The following is a description of a gene set: Inflammatory genes down-regulated in mammary carcinoma cells after stimulation with TGFB1 for 1 hr. Mouse Gene Set: BIERIE_INFLAMMATORY_RESPONSE_TGFB1 Transforming growth factor (TGF)-beta signaling has been associated with early tumor suppression and late tumor progression; however, many of the mechanisms that mediate these processes are not known. Using Cre/LoxP technology, with the whey acidic protein promoter driving transgenic expression of Cre recombinase (WAP-Cre), we have now ablated the type II TGF-beta receptor (T beta RII) expression specifically within mouse mammary alveolar progenitors. Transgenic expression of the polyoma virus middle T antigen, under control of the mouse mammary tumor virus enhancer/promoter, was used to produce mammary tumors in the absence or presence of Cre (T beta RII((fl/fl);PY) and T beta RII((fl/fl);PY;WC), respectively). The loss of TGF-beta signaling significantly decreased tumor latency and increased the rate of pulmonary metastasis. The loss of TGF-beta signaling was significantly correlated with increased tumor size and enhanced carcinoma cell survival. In addition, we observed significant differences in stromal fibrovascular abundance and composition accompanied by increased recruitment of F4/80(+) cell populations in T beta RII((fl/fl);PY;WC) mice when compared with T beta RII((fl/fl);PY) controls. The recruitment of F4/80(+) cells correlated with increased expression of known inflammatory genes including Cxcl1, Cxcl5, and Ptgs2 (cyclooxygenase-2). Notably, we also identified an enriched K5(+) dNp63(+) cell population in primary T beta RII((fl/fl);PY;WC) tumors and corresponding pulmonary metastases, suggesting that loss of TGF-beta signaling in this subset of carcinoma cells can contribute to metastasis. Together, our current results indicate that loss of TGF-beta signaling in mammary alveolar progenitors may affect tumor initiation, progression, and metastasis through regulation of both intrinsic cell signaling and adjacent stromal-epithelial interactions in vivo. studied in species Mus musculus from publication Bierie B, Stover DG, Abel TW, Chytil A, Gorska AE, Aakre M, Forrester E, Yang L, Wagner KU, Moses HL (PMID 18339861), and this is the list of marker genes: Cxcl5, Myc, Cxcl1, Ptgs2, Ccl20